The following is a description of a gene set: part of: Sphingolipid metabolism Reactome Pathway: Glycosphingolipid metabolism The steps involved in the synthesis and degradation of glycosphingolipids (sphingolipids with one or more sugars attached) are annotated here (the topic is reviewed by Gault et al. 2010; Sandhoff & Sandhoff, 2018; Sandhoff et al, 2018). species: Homo sapiens, and this is the list of marker genes: NEU1, ST6GALNAC6, B4GALT6, ARSD, GLB1L, SMPD3, PSAP, B3GALT4, UGCG, NEU2, STS, SUMF2, ARSJ, ST6GALNAC5, UGT8, A4GALT, ARSF, ST8SIA5, ARSI, GBA2, FUT2, SMPD4, ARSG, CERK, GLB1L2, GAL3ST1, B4GALT5, ASAH1, GALC, B4GALNT1, NEU4, GLB1, SUMF1, ST3GAL2 (ST3 beta-galactoside alpha-2,3-sialyltransferase 2), M6PR, GBA1, B3GALNT1, ARSB, GLB1L3, CTSA, FUT1, HEXA, ARSH, SMPD1, GM2A, ENPP7, ST3GAL3, ASAH2, HEXB, NEU3, ARSK, GBA3, ARSA, ST3GAL5, ARSL, SMPD2, GLA, B3GNT5